The following is a description of a gene set: species: Mus musculus TP53 Regulates Transcription of DNA Repair Genes Mouse Gene Set: REACTOME_TP53_REGULATES_TRANSCRIPTION_OF_DNA_REPAIR_GENES, and this is the list of marker genes: Polr2k, Polr2f, Mnat1, Ercc2, Polr2c, Polr2i, Tcea1, Polr2a, Polr2h, Nelfcd, Polr2g, Ctdp1, Eloc (elongin C), Polr2d, Cdk12, Polr2b, Eloa, Gtf2h1, Gtf2h4, Polr2e, Ccnh, Gtf2h5, Ercc3, Gtf2h3, Ccnk (NCBI Gene Id 12454), Ccnt2, Nelfa, Supt5, Polr2l, Nelfb, Ssrp1, Gtf2f1 (NCBI Gene Id 98053), Supt4a, Nelfe, Cdk13, Cdk7, Elob (elongin B), Supt16, Gtf2h2, Ccnt1, Cdk9, Gtf2f2, Ell